The following is a description of a gene set: The process in which the anatomical structures of the mesonephric duct are generated and organized. A mesonephric duct is a tube drains the mesonephros. species: Mus musculus Mouse Gene Set: GOBP_MESONEPHRIC_DUCT_MORPHOGENESIS, and this is the list of marker genes: Wnt9b, Mir216b, Hnf1b, Gpc3 (NCBI Gene Id 14734), Osr1, Mir216a, Mir217